Given this list of marker genes Cnot6, Ago3, Mir196a-2, Cnot7, Ago2, Mov10, Mir196b, Mir196a-1, Cnot8, here is a description of the gene set: species: Mus musculus Mouse Gene Set: GOBP_MIRNA_MEDIATED_GENE_SILENCING_BY_MRNA_DESTABILIZATION An RNA interference pathway in which microRNAs (miRNAs) direct the cleavage of target mRNAs. Once incorporated into a RNA-induced silencing complex (RISC), a miRNA base pairing with near-perfect complementarity to the target mRNA will typically direct targeted endonucleolytic cleavage of the mRNA. Many plant miRNAs downregulate gene expression through this mechanism.